Given this list of marker genes Ldlr, G6pc1, Chac1, Gsta1, Nfe2l2, Apoe, Fasn, Nqo1 (NCBI Gene Id 18104), Sirt2 (sirtuin 2), Ddit3, Acacb, Gsta4, Gad2 (glutamic acid decarboxylase 2), here is a description of the gene set: A change in state or activity of a cell or an organism (in terms of movement, secretion, enzyme production, gene expression, etc.) as a result of a caloric restriction, insufficient food energy intake. species: Mus musculus Mouse Gene Set: GOBP_RESPONSE_TO_CALORIC_RESTRICTION